The following is a description of a gene set: Genes predicted to be targets of miRBase v22 microRNA mmu_miR_3962 in miRDB v6.0 with MirTarget v4 prediction scores > 80 (high confidence targets). Mouse Gene Set: MIR_3962 from publication Chen Y, Wang X (PMID 31504780) studied in species Mus musculus, and this is the list of marker genes: Il23a, Lrig2, Ticam2, Rell1, Katnip, Eef2k, Clint1, Fnip1, Zfp182, Ano1, Csad, Memo1, Ccdc39, Prtg, Zfp385b, Tmprss11a, Kif13a, Cep350, Hoxb7, Map4k3, Gata6, Cdkn2aip (CDKN2A interacting protein), Rnls, Tars1, Aldh1a3, Rnf180, Pim2, Meioc, Arhgap29 (NCBI Gene Id 99822), Klrd1, Tmem106b, Pate2, Plxnc1, Spint4, Ark2n, Zcchc3, Map7, Gtf3c4